The following is a description of a gene set: studied in species Homo sapiens Human Gene Set: GOBP_NONASSOCIATIVE_LEARNING A simple form of learning whereby the repeated presence of a stimulus leads to a change in the probability or strength of the response to that stimulus. There is no association of one type of stimulus with another, rather it is a generalized response to the environment., and this is the list of marker genes: SHANK1, DRD1, MAPK8IP2, EPM2A, COMT, HTR2A, DRD5